Given this list of marker genes CLDN6, PRKCI, CLDN2, CLDN12, CLDN7, CLDN14, CLDN23, CLDN1, CLDN17, CLDN8, CLDN18, CLDN16, CLDN3, PARD3, PARD6A, PATJ, CLDN9, CLDN19, F11R, CLDN20 (NCBI Gene Id 49861), PARD6G, CLDN11, CLDN5 (claudin 5), PARD6B, CLDN10, CLDN22, CLDN4, CLDN15, PALS1, CRB3, here is a description of the gene set: Tight junction interactions Human Gene Set: REACTOME_TIGHT_JUNCTION_INTERACTIONS species: Homo sapiens